The following is a description of a gene set: species: Homo sapiens Human Gene Set: GSE1925_CTRL_VS_3H_IFNG_STIM_IFNG_PRIMED_MACROPHAGE_DN from publication Hu X, Park-Min KH, Ho HH, Ivashkiv LB (PMID 16148108) IFN-gamma transcriptional responses in control and IFN-gamma primed primary human macrophages Genes down-regulated in macrophages primed by IFNG: untreated versus stimulated by IFNG for 3h., and this is the list of marker genes: PROS1, CD3G, GLRX, TBC1D14, TNFRSF18, PKD2, INPP5K, ENO2 (enolase 2), CA2, HOMER2, S100A13, SERPINI1, MED12L, TSEN15, CHRNA6, PMS2, ADGRE1, CHCHD5, RPTN, PLOD3, CDR2L (cerebellar degeneration related protein 2 like), ZCCHC3, DHRS3, IGF2BP1, RNF14, VCL, BDKRB1, CYP19A1, ADAM12, FKBPL, NR0B1, RTL6 (retrotransposon Gag like 6), PEG3, ADPRM, RNF167, USP12, PFKM, TPMT, FABP4, SPIB, JARID2, SLC35A4, SDC4, WDFY2, PTX3, CAPN5, FKBP7, TMED1, ELOVL2, ZNF865, TRPV2, NEFL, ANAPC16, TMEM230, EPHA2, NMRK1, GNPDA1, TBCE, CTTN, SLC12A1, EMP1, LTK, SCAF8, RAB3D, NUDT5, FOXB1, JPH3, PHC1, DENND5A, NNAT, PKHD1, SLC26A2, RBM39, PTK2, CDKN1A, DAB2IP, ABCB10 (ATP binding cassette subfamily B member 10), PTTG1, BTC, NIFK, C19orf12, TRAF3IP2, CHIC1, FHOD3, ANXA10, H3C7, ZNF23, DNAJB8, WNT5B, MYF5, CXADR, PKIA, DPP7 (dipeptidyl peptidase 7), ZNF22, ZNF600, BCL2L1, CA12, GPRASP1, TMEFF1, XRN2, WLS, FAS, COMMD5, PPARGC1A, KDELR3, LDHB, GTF3C1, MLF2, MTM1, ANAPC2, PPP1R21, CNGA1, CHGB, CAPN3, IL13RA2, GJA10, RAD52, RYR2, MMP14, MCOLN2, PSMB1 (NCBI Gene Id 5689), UBAP2L, MCAM, ITGAL, CEBPB, SLC7A7, NUP50, TRIM27, SETD4, SPECC1, SMOC1, UBA5, FGF12, TYRO3, ITGA6, PARM1, TRABD, JCHAIN, NEK1, SMYD1, ZBTB20, SGCB, NIT1, WDR83OS, BEX4, MGMT, CAPZA3, AFF1, CACHD1, NKIRAS1, CAVIN3, TLR6, ACBD6, HSD11B1, TNFRSF9, MTOR, PTGR1, DICER1, SCPEP1, CENPE, SLC66A3, TGDS, PAWR, CASP12, LAPTM4B, PADI4, GABRB3, MAPK10, ADPRH, SRPK2, NXF1, CDX2, HTR2C, SEMA5A, H19, UIMC1, OGDH, VCP, PHAF1, HCK, CRMP1, KERA, INPPL1 (inositol polyphosphate phosphatase like 1), MAGED2 (NCBI Gene Id 10916), CRTAP, TUBGCP4, DNASE1L1, GALNT11, GAB1, HARS1, ABHD5, SLC44A1, ST7, TMEM106C, SYT9, MRPL35 (NCBI Gene Id 64980), DSG2, CLEC16A (NCBI Gene Id 441746), MEN1, NFKBIA